Given this list of marker genes Cps1, Dpysl5, Dpys, Umps (NCBI Gene Id 73572), Dhodh, Dpysl2, Mtor, Mapk1, Ctps1, Rrm1, Tymp, Aldh6a1, Dpyd, Cad, Tyms, Dpysl4 (dihydropyrimidinase-like 4), Dpysl3, Ctps2, Cmpk1, Crmp1, Tet2, here is a description of the gene set: Mouse Gene Set: GOBP_PYRIMIDINE_NUCLEOBASE_METABOLIC_PROCESS species: Mus musculus The chemical reactions and pathways involving pyrimidine nucleobases, 1,3-diazine, organic nitrogenous bases.